The following is a description of a gene set: studied in species Homo sapiens Human Gene Set: REACTOME_PLATELET_AGGREGATION_PLUG_FORMATION Platelet Aggregation (Plug Formation), and this is the list of marker genes: RAP1B, SRC, MPL, PDPK1, APBB1IP, BCAR1, GRB2, ITGA2B, PTPN1, GP1BB, RASGRP2, F2, GP1BA, ADRA2C, GP9, GP5, ITGB3, RAP1A, THPO, AKT1, SHC1, ADRA2B, FGA, FGB, PTK2, COL1A2, RAPGEF4, TLN1, ADRA2A, COL1A1, RASGRP1, CRK, FN1, VWF (von Willebrand factor), RAPGEF3, CSK, FGG, SOS1, SYK